Given this list of marker genes CBLN2, NRXN1, NRXN3, GRID2, CBLN1, GRID1, here is a description of the gene set: Human Gene Set: GOCC_TRANS_SYNAPTIC_PROTEIN_COMPLEX species: Homo sapiens A protein complex that spans the synaptic cleft and has parts in both the pre- and post-synaptic membranes.